Given this list of marker genes Mia3, Cideb, Ap3d1, Insig1, Surf4, Mia2, Sec24d, Ap3s2, Sec24a, Sec31b, Scap, Sar1b, Rab1a, Sar1a, Tbc1d20 (TBC1 domain family, member 20), Ap3m1, Sec23a, Sec23b, Ap3m2, Kif13a, Sec31a, Ap3b2, Picalm, Ap3b1, Sec24b, Sec13, Sec24c, Ap3s1, here is a description of the gene set: Mouse Gene Set: GOBP_VESICLE_CARGO_LOADING The formation of a macromolecular complex between the coat proteins and proteins and/or lipoproteins that are going to be transported by a vesicle. species: Mus musculus